Given this list of marker genes MGST3, MGST2, GSTA2, GSTA4, GSTZ1, GSTM2, GSTA3, GSTM4, GSTP1, GSTM5, here is a description of the gene set: Human Gene Set: MODULE_101 studied in species Homo sapiens Genes in the cancer module 101.